The following is a description of a gene set: The transcription factor FoxP3 partakes dominantly in the specification and function of FoxP3+ CD4+ T regulatory cells (Tregs), but is neither strictly necessary nor sufficient to determine the characteristic Treg transcriptional signature. Computational network inference and experimental testing assessed the contribution of several other transcription factors (TFs). Enforced expression of Helios or Xbp1 elicited specific signatures, but Eos, Irf4, Satb1, Lef1 and Gata1 elicited exactly the same outcome, synergizing with FoxP3 to activate most of the Treg signature, including key TFs, and enhancing FoxP3 occupancy at its genomic targets. Conversely, the Treg signature was robust to inactivation of any single cofactor. A redundant genetic switch thus locks-in the Treg phenotype, a model which accounts for several aspects of Treg physiology, differentiation and stability. species: Homo sapiens from publication Fu W, Ergun A, Lu T, Hill JA, Haxhinasto S, Fassett MS, Gazit R, Adoro S, Glimcher L, Chan S, Kastner P, Rossi D, Collins JJ, Mathis D, Benoist C (PMID 22961053) Genes up-regulated in CD4 T conv: control versus over-expression of PBX1 and FOXP3. Human Gene Set: GSE40274_CTRL_VS_FOXP3_AND_PBX1_TRANSDUCED_ACTIVATED_CD4_TCELL_UP, and this is the list of marker genes: CSF3R, GYPA, MOSPD1, MICAL1, FCRL5, DDX17, RIGI (NCBI Gene Id 23586), IQGAP2, GALNT10, ETS1, IFNGR1, VAMP5, HIVEP2, HCFC2, TSPO2, PRKAB1, PLA2G15, PRF1, DGKD, GTF2IRD1, CCDC102A, TLN1, PCYT1B, SLC25A53, GPR155, RHOH, SLC28A2, PHETA2, NLRC4, MEIS3, PXK, F13A1, MBOAT1, P2RY14, KLF2, HDAC10, SNX8, JAML, BRWD1, THRB, DUSP10, GP9, FKBP14, PIK3C2B, CHODL, FAM193B, SLC2A3, PRKD2, MAST4, HES1, RAVER2, SLC8A1, TNFRSF21, MCTP2, ST6GAL1, RMI1, IL10RB, RNF167, CREBBP, SPNS3, ZNF483, STX2, CRIP1, SCEL, UNC5A, SLC16A9, MMP9, DHRS9, BPTF, GABPB2, LILRB3, NIPAL3, MKI67, ACSL6, BCL6, MFSD8, NGRN, PRR5, PADI2, ROCK1, SAMHD1, CLK3 (CDC like kinase 3), TNRC6B, SLC41A3, EPS8L1, B3GALT5, FGL2, AP1S3, RASGRP1, CPOX, MAPK11, SLC25A37, MIR7-1, NRP1 (neuropilin 1), HACD1, RBM43, IL2RB, CPM, B3GALT4, ATF7, MFSD2B, NXPE3 (NCBI Gene Id 91775), ARID1A (AT-rich interaction domain 1A), ITGA9, ANKRD44, ADAMTS14, SPIRE1, RYR2, TSPAN32, CUEDC1, KIDINS220, CLNK, DENND6A, TRPM2 (transient receptor potential cation channel subfamily M member 2), LCP2, PSD4 (NCBI Gene Id 23550), BTLA, DEPDC5, PHLDA2, KIZ, CERS4, NOTCH2, CCDC69 (coiled-coil domain containing 69), IL10RA, KLHL6, CNP, HHEX, DPP4, ISG20, TENM4, ITSN2, XKRX, CHST15, THEMIS2, ARAP2, LGMN, RHBDL1, GIMAP3P, RNF145, TGM1, TGM4, TRERF1, CCR3, FNDC7 (NCBI Gene Id 163479), MARCHF8, CDH17, ABLIM1, CDK14, PARP6, SAFB2, EXOC6, CYTH3, STRBP, DNMBP, PGGHG, IL1RL1, HYKK, ZNF148 (zinc finger protein 148), PLAUR, SLC35A5, CKLF, KIF21B, PRKAR2B (protein kinase cAMP-dependent type II regulatory subunit beta), GDPD3, CYRIB